The following is a description of a gene set: from publication Winnepenninckx V, Lazar V, Michiels S, Dessen P, Stas M, Alonso SR, Avril MF, Ortiz Romero PL, Robert T, Balacescu O, Eggermont AM, Lenoir G, Sarasin A, Tursz T, van den Oord JJ, Spatz A, Melanoma Group of the European Organization for Research and Treatment of Cancer (PMID 16595783) studied in species Homo sapiens Human Gene Set: WINNEPENNINCKX_MELANOMA_METASTASIS_DN Genes from the 254-gene classifier which were down-regulated in melanoma patients with a reported distant metastasis within 4 years. BACKGROUND: Gene expression profiling data for human primary cutaneous melanomas are scarce because of the lack of retrospective collections of frozen tumors. To identify differentially expressed genes that may be involved in melanoma progression and prognosis, we investigated the relationship between gene expression profiles and clinical outcome in a cohort of patients with primary melanoma. METHODS: Labeled complementary RNA (cRNA) from each tissue sample was hybridized to a pangenomic 44K 60-mer oligonucleotide microarray. Class comparison and class prediction analyses were performed to identify genes whose expression in primary melanomas was associated with 4-year distant metastasis-free survival among 58 patients with at least 4 years of follow-up, distant metastasis, or death. Results were validated immunohistochemically at the protein level in 176 independent primary melanomas from patients with a median clinical follow-up of 8.5 years. Survival was analyzed with a Cox multivariable model and stratified log-rank test. All statistical tests were two-sided. RESULTS: We identified genes that were associated with distant metastasis-free survival of patients with primary melanoma. These genes include genes involved in activating DNA replication origins, such as minichromosome maintenance genes and geminin. Twenty-three of these genes were studied at the protein level; expression of five (MCM4, P =.002; MCM3, P =.030; MCM6, P =.004; KPNA2, P =.021; and geminin, P =.004) was statistically significantly associated with overall survival in the validation set. In a multivariable Cox model adjusted for tumor thickness, ulceration, age, and sex, expression of MCM4 (hazard ratio of death = 4.04, 95% confidence interval = 1.39 to 11.76; P =.010) and MCM6 (HR of death = 7.42, 95% CI = 1.99 to 27.64; P =.003) proteins was still statistically significantly associated with overall survival. CONCLUSION: We identified genes whose expression was associated with metastatic dissemination of cutaneous melanomas. These genes may shed light on the molecular mechanisms underlying poor prognosis in melanoma patients., and this is the list of marker genes: STMN2, PROM2, LGALS2, PIK3IP1, HLA-DQB1, PTGDS, CD1C, LSP1, HOXA9, KRTAP19-1 (NCBI Gene Id 337882), CLEC3B, DPYSL2, CLEC10A, KCTD11, P2RY14, GPRIN2, SPINT2, ST6GALNAC6, LTB, CD1A, GABPB1-IT1, F10, TXNIP, XCL1, EMX2OS, RNF125, CEBPA, CRY2, CST5, PI16, EMX2, ST7-AS1, SPPL3, ALDH3A2, CEP170B, CLIC3, KIAA0930, PCP4, TOM1L2, CST3, CXCL14, CA5B, FGD3, CTNNBIP1, DHRS1